The following is a description of a gene set: Human Gene Set: HP_CEREBRAL_EDEMA Abnormal accumulation of fluid in the brain. studied in species Homo sapiens Cerebral edema, and this is the list of marker genes: PRRT2, ASL, TRAF3, ACADM, KCNQ2, LIAS, TLR3, RANBP2, ESAM, MRPL39, DBR1, CPS1, C1QBP, CPSF3, SMS, ATP1A2, COX16, UNC93B1, TBK1, SCN1A, NDUFS4, ASS1, SLC25A13, CACNA1A, TICAM1, NAXD, LAMA2, BCKDHA, CPT2, NAXE, OTC, ACAD9